The following is a description of a gene set: Delayed tooth eruption affecting the primary dentition. Delayed eruption of primary teeth studied in species Homo sapiens Human Gene Set: HP_DELAYED_ERUPTION_OF_PRIMARY_TEETH, and this is the list of marker genes: RAI1, LEMD2, FLII, FGFR2, CAMK2B (calcium/calmodulin dependent protein kinase II beta, NCBI Gene Id 816), CTSK, RUNX2 (RUNX family transcription factor 2), NDUFB11, EDNRA, CBFB, ERCC8, ANKH, DEAF1, ERCC6, ERCC4, ERCC1, IQSEC2